Given this list of marker genes GPC6, EFNB1, CHRNG, ITGB4, CHUK, RIPK4 (receptor interacting serine/threonine kinase 4), MYH3, PAX3, PLEC, ADGRG6, TAF4, here is a description of the gene set: species: Homo sapiens Presence of a cutaneous membrane (flap) in the armpit. Axillary pterygium Human Gene Set: HP_AXILLARY_PTERYGIUM